Given this list of marker genes PHIP, ARG2, SMAD1, WDR37, SLC46A3, TRIM5, TMED2, RREB1, TRIM52, GDE1, PCMTD2, UGP2, MT1HL1, LIPA, MT1G, TMEM127, CAMK2G, PTGER2, INPP4B, KCNJ12, VGLL4, ZBTB24, TTC9, GABPB1, KRAS, MT1H, NME3, RGS9 (regulator of G protein signaling 9), TAF7, CD164, PLIN2, NRIP3, GAB2, OPHN1 (NCBI Gene Id 4983), ISG20 (NCBI Gene Id 3669), SNAP23, DNASE1L1, KRBOX4, PARP4 (poly(ADP-ribose) polymerase family member 4, NCBI Gene Id 221181), NCOA3, HEXA, RSBN1 (round spermatid basic protein 1), HOMER2, FAM200C, RNF125, FILIP1L, ZDHHC4, CCDC22, FAM171A1, IL4, TMEM187, RTF1, FBXW2, ACP5, DENND4C (NCBI Gene Id 55667), HERC3, PEX11B, HERC4 (NCBI Gene Id 63907), PTGER4, AMPD3, LNPEP, ZFYVE21, CAPNS1, RBM26, PLPP1, AKAP11, RSAD2, MBD5, KRCC1, FOXD2, RHOF, TP53TG1, TIPRL, PLXNC1, ICAM3, RNF170, BFAR, PRKCA, RPN2, PLCL2, SP140L, PRKCQ, CDCP1, SSR1, DROSHA, SMAD2, SCPEP1, SGSH, EFCAB14, BTN3A3 (butyrophilin subfamily 3 member A3), EML4, MKRN1, CHCHD7, IL17RB, RASA1, MGAT1 (NCBI Gene Id 4245), SETX, FOXO1, MT1E, PTTG1IP, AGPAT1, IL5, ACAP2, PARP11, ARPC5, SDCBP, ERN1, GIMAP6, CASD1, ATP6V0E1, RGS14, SCP2, GIN1, TAF5L (TATA-box binding protein associated factor 5 like), PHTF1, ZNF274, ZNF623, PRKX, PKD2, EGLN3 (NCBI Gene Id 63900), LRIG2, MARCHF8, ANKRD10, PGLS (6-phosphogluconolactonase), ELF4, VPS4B, ZNF468, NMT2 (N-myristoyltransferase 2), RPRD2, DOCK2, TRNAU1AP, ZNF267 (zinc finger protein 267), PTPN14, ANGEL2, CDK19, TRAPPC8, DNAJB9, MAN1B1, PRNP, PTPRA, RFPL1S, GNAQ, MT1F, ZMYM1, BBS10, RUNX1, PLCL1, MAX, ZNF131, H2BC8, TXNDC15, NT5C2, LPIN2, SH3BGRL, ADAR, ARHGAP26, LRIG1, TCIRG1, CTAGE9, GZMA, JAK2, SLC35E3, WASF2, PLA2G4A, PHKB, ZNF217, H2AC11, CAB39, CLGN, SLC11A2, FOXN3, RNF11, RBM47, AKAP13, PDE4A, ACTR2, ADAMTS13, NAGPA, SSR2, ZNF175, XPNPEP3, CRLF3, ZNF45, RALGAPB, PIK3R1, LAPTM4A, CNIH1, IL4R, IL10RB, PSMB9, DPYD, PARP12, EDEM3, CLDND1, RTN3, IMPACT, AFF1, APOL1, HEXB, DUSP7, here is a description of the gene set: studied in species Homo sapiens Human Gene Set: GSE22886_TH1_VS_TH2_48H_ACT_DN Immune cell-specific expression is one indication of the importance of a gene's role in the immune response. In order to identify such patterns, we set out to broadly profile gene expression in a variety of immune cells. from publication Abbas AR, Baldwin D, Ma Y, Ouyang W, Gurney A, Martin F, Fong S, van Lookeren Campagne M, Godowski P, Williams PM, Chan AC, Clark HF (PMID 15789058) Genes down-regulated in comparison of stimulated CD4 Th1 cells at 48 h versus stimulated CD4 Th2 cells at 48 h.